The following is a description of a gene set: species: Homo sapiens Binding to the delta subunit of the catenin complex. Human Gene Set: GOMF_DELTA_CATENIN_BINDING, and this is the list of marker genes: PTPRJ, CDH24, CCDC85B, DACT3, PTPRT, PLEKHA7, PLPP3, CDH26, ABL1, DACT2, DACT1